Given this list of marker genes Nherf1 (NHERF family PDZ scaffold protein 1), Apod, Fshr, Myocd, Cbl, Lrp1, Phf14, Ptgir, Cblb, Src, Lox, Ptpn2, Hip1r, Ndrg4, Npr2, Snca, Ift20, F7 (coagulation factor VII), Ptprj, F3, Adipoq, Hip1, Hgs, Lrig2, Inppl1, Nrp1, here is a description of the gene set: Any process that modulates the frequency, rate or extent of the platelet-derived growth factor receptor signaling pathway. Mouse Gene Set: GOBP_REGULATION_OF_PLATELET_DERIVED_GROWTH_FACTOR_RECEPTOR_SIGNALING_PATHWAY studied in species Mus musculus